Given this list of marker genes KAZN, GABRQ, SLC4A5, CD14, WASF2, MKNK2, SDF4, IPMK, RAP1GAP, SKIL, DDX46, SNRNP200, PIGY, ZSWIM9, SLC16A3, KIF20B, HCAR2, NCEH1, PRIM2, TMEM26, SGMS2, ZDHHC24, ATP6V1G2, NUP43, PARD6A, GCNT3, ZEB1, NCOA2, MICU2, VPS37B, PPBP, THEMIS2, ATP10D, COQ8A, RNF41, NFIB, SUPT5H, FOSL2 (FOS like 2, AP-1 transcription factor subunit), WNT3, MGARP, PEX11B, IRAK2 (interleukin 1 receptor associated kinase 2), CEP120, IL2RG, ENKD1, PLIN2, CD81, APBB3, SLA, CPOX, IRX6, SNX32, CHRND, TMEM123, GDF11, P2RY10, FAM98A, CSNK1E, SNX13, ORM1, CHRNA7 (NCBI Gene Id 1139), CCR7, MXI1, VCAN, DUSP10, RNF152, KIF23, SIRT5, BCL6, NPLOC4, EPRS1, RAD51, SORBS3, SLC16A6, MTMR3, CCN5, SAMD12, SPINT4, MGAT4C, RNF11, KCNK10, CHD2, H2AZ1, HIF1A, BCORL1, FAP, ADAMTS4, ING4, MYL12B, WNT6 (Wnt family member 6), TERB2, RAP2A, NUDT4, PWWP3B, MOG, IRF6, NFXL1, IRS2, DUSP4, DYNLT5, RELL1, FAM193B, SH3RF1, KRT36, ISY1, P2RY1, C11orf54, TG (NCBI Gene Id 7038), TNFRSF21 (TNF receptor superfamily member 21), SOWAHC, RNF157, ENGASE, TSG101, TSNAX, ARPC3, PHF13, TMEM45A, VSX1, CCDC117, NDC80, PLEKHS1, EML1, GALNT2, FXYD7, PARP8, URGCP, DHX16, BNIP2, MORF4L2, CORO1C, NBEAL1, GALNT3, STAT3, SNX18, NR4A2, CLCA1 (chloride channel accessory 1), ARPC5, MDH2, SCLY, GADD45B, KIAA0586, REM2, PDCD1, DCTN4, NXN, WDR73, LRRC4, HP, DUSP1, ACOX2, TPD52, NOP53, ARL4A, C9orf72, KPNA7, NCKAP1L, DNAJC5B, DCDC2B, DDX52, MADCAM1, GNA13, FGF14, CHST11, AEBP2, HHIPL2, CA4, RNF19A (NCBI Gene Id 81036), AP3B1, ADH1C, POU6F1, SH3BP4, COP1, RHOC, GSKIP, BICC1, ANAPC1 (anaphase promoting complex subunit 1), ZC3HAV1, TRIM68, MADD, LRIG2, ARHGAP31 (NCBI Gene Id 57514), JUND (JunD proto-oncogene, AP-1 transcription factor subunit), TNFAIP3, DUSP5, ZC3H11A, RB1CC1, SH3BP5, ZNF616, LACTB, AFF1, C6orf58, LRP4, OLFML2A, B4GALT5, P4HB, UPB1, PSME4, POLR1C, TMEM158, CRBN, here is a description of the gene set: from publication Austenaa L, Barozzi I, Chronowska A, Termanini A, Ostuni R, Prosperini E, Stewart AF, Testa G, Natoli G (PMID 22483804) species: Homo sapiens Histone methyltransferases catalyze site-specific deposition of methyl groups, enabling recruitment of transcriptional regulators. In mammals, trimethylation of lysine 4 in histone H3, a modification localized at the transcription start sites of active genes, is catalyzed by six enzymes (SET1a and SET1b, MLL1–MLL4) whose specific functions are largely unknown. By using a genomic approach, we found that in macrophages, MLL4 (also known as Wbp7) was required for the expression of Pigp, an essential component of the GPI-GlcNAc transferase, the enzyme catalyzing the first step of glycosylphosphatidylinositol (GPI) anchor synthesis. Impaired Pigp expression in Wbp7-/- macrophages abolished GPI anchor-dependent loading of proteins on the cell membrane. Consistently, loss of GPI-anchored CD14, the coreceptor for lipopolysaccharide (LPS) and other bacterial molecules, markedly attenuated LPS-triggered intracellular signals and gene expression changes. These data link a histone-modifying enzyme to a biosynthetic pathway and indicate a specialized biological role for Wbp7 in macrophage function and antimicrobial response. Human Gene Set: GSE30971_WBP7_HET_VS_KO_MACROPHAGE_UP Genes up-regulated in bone marrow-derived macrophages: heterozygous versus homozygous knockout of MLL4.